The following is a description of a gene set: Human Gene Set: HP_NEUROFIBRILLARY_TANGLES Pathological protein aggregates formed by hyperphosphorylation of a microtubule-associated protein known as tau, causing it to aggregate in an insoluble form. Neurofibrillary tangles studied in species Homo sapiens, and this is the list of marker genes: MAPT, VPS13C, PLAU, CHMP2B, APP, TREM2, ITM2B, MPO, APOE, GRN, TOMM40, VCP, NPC2, PRNP, TMEM106B, ABCA7, PLA2G6, NPC1, PSEN1, NOS3, CYLD, PSEN2, SORL1